The following is a description of a gene set: species: Homo sapiens from publication Turashvili G, Bouchal J, Baumforth K, Wei W, Dziechciarkova M, Ehrmann J, Klein J, Fridman E, Skarda J, Srovnal J, Hajduch M, Murray P, Kolar Z (PMID 17389037) Genes up-regulated in lobular carcinoma vs normal ductal breast cells. BACKGROUND: Invasive ductal and lobular carcinomas (IDC and ILC) are the most common histological types of breast cancer. Clinical follow-up data and metastatic patterns suggest that the development and progression of these tumors are different. The aim of our study was to identify gene expression profiles of IDC and ILC in relation to normal breast epithelial cells. METHODS: We examined 30 samples (normal ductal and lobular cells from 10 patients, IDC cells from 5 patients, ILC cells from 5 patients) microdissected from cryosections of ten mastectomy specimens from postmenopausal patients. Fifty nanograms of total RNA were amplified and labeled by PCR and in vitro transcription. Samples were analysed upon Affymetrix U133 Plus 2.0 Arrays. The expression of seven differentially expressed genes (CDH1, EMP1, DDR1, DVL1, KRT5, KRT6, KRT17) was verified by immunohistochemistry on tissue microarrays. Expression of ASPN mRNA was validated by in situ hybridization on frozen sections, and CTHRC1, ASPN and COL3A1 were tested by PCR. RESULTS: Using GCOS pairwise comparison algorithm and rank products we have identified 84 named genes common to ILC versus normal cell types, 74 named genes common to IDC versus normal cell types, 78 named genes differentially expressed between normal ductal and lobular cells, and 28 named genes between IDC and ILC. Genes distinguishing between IDC and ILC are involved in epithelial-mesenchymal transition, TGF-beta and Wnt signaling. These changes were present in both tumor types but appeared to be more prominent in ILC. Immunohistochemistry for several novel markers (EMP1, DVL1, DDR1) distinguished large sets of IDC from ILC. CONCLUSION: IDC and ILC can be differentiated both at the gene and protein levels. In this study we report two candidate genes, asporin (ASPN) and collagen triple helix repeat containing 1 (CTHRC1) which might be significant in breast carcinogenesis. Besides E-cadherin, the proteins validated on tissue microarrays (EMP1, DVL1, DDR1) may represent novel immunohistochemical markers helpful in distinguishing between IDC and ILC. Further studies with larger sets of patients are needed to verify the gene expression profiles of various histological types of breast cancer in order to determine molecular subclassifications, prognosis and the optimum treatment strategies. Human Gene Set: TURASHVILI_BREAST_LOBULAR_CARCINOMA_VS_DUCTAL_NORMAL_UP, and this is the list of marker genes: NAA15, PRRX1, BGN, COL5A1, CILP, LOX, C5AR1, CD69, SULF2, TAGAP, HSPA6, COL1A1, IGF1, RAB18 (NCBI Gene Id 22931), SSR1, COL3A1, COL6A3, WIPF1, ZNF117, PLXNC1, UBTD2, ADAM12, TIE1, IFI44, FNDC1, EDNRA, CCN4, ENSG00000280119, UXS1, POSTN, COL8A1, COL5A2, LRRC15, LAMB1, SPAG9, COL11A1, CXCR4, FN1, GNA13, ASPN, COL1A2, VCAN, SPARC, ASAP1, COMP, INHBA, PRC1 (NCBI Gene Id 9055), AGTPBP1, SULF1, RAP2C, MXRA5, RGS1, THY1, DOCK1, AEBP1, CTHRC1, COL12A1, SMCHD1, ZEB1, MIR1245A, PLXDC1 (NCBI Gene Id 57125), THBS2, SFRP2, LYZ, FBN1, ENPEP (NCBI Gene Id 2028), FBXO28, GPX8, MICAL2